The following is a description of a gene set: High-pitched cry studied in species Homo sapiens Human Gene Set: HP_HIGH_PITCHED_CRY A type of crying in an abnormally high-pitched voice., and this is the list of marker genes: ALPL, FIG4, ATP1A3, ABAT, PNPO, MECP2, ATP5F1A